The following is a description of a gene set: The process whose specific outcome is the progression of the pancreas over time, from its formation to the mature structure. The pancreas is an endoderm derived structure that produces precursors of digestive enzymes and blood glucose regulating hormones. species: Mus musculus Mouse Gene Set: GOBP_PANCREAS_DEVELOPMENT, and this is the list of marker genes: Cftr (cystic fibrosis transmembrane conductance regulator), Hhex, Shh, Rfx6, Foxf1, Igf2, Wfs1, Onecut2, Rfx3, Gip, Neurod1, Igf1r, Onecut1, Srp54a, Bmp6, Mir541, Ccdc39, Mnx1, Mir214, Sox9, Gata6 (NCBI Gene Id 14465), Hes1, Pde3b, Selenot, Wnt5a, Bad, Il6ra, Dnaaf1, Met, Nphp3, Gipr, Clock, Foxa2 (forkhead box A2), Nkx6-2, Ctnnb1, Zfp800, Rbm4, Igf1, Insr, Sox4, Mir375, Acvr2b, Cdh2, Hnf1b, Smo, Wls, Eif2ak3, Men1, Il6, Reg1, Cela1, Pax2, Zic3, Insm1, Ier3ip1, Pcsk1, Cdk6, Clu, Nkx6-1, Fgf10, Myt1, Prox1, Ptf1a, Bmp5, Bmal1, Invs, Aldh1a2, Nkx2-2, Mir503, Bglap2, Sidt2, Meis2, Ccdc40 (NCBI Gene Id 277022), Bhlha15, Pax6, Gdf11, Ildr2, Pdpk1, Pax4, Rheb, Mir7-1, Ift88, Dll1, Nkx3-2, Ihh, Vhl, Xbp1, Isl1, Nr5a2, Pdx1, Hnf1a, Bmp4, Bak1, Ptprv, Smad2